Given this list of marker genes Calhm4, Calhm2, Calhm5, Calhm1, Calhm3, Slc17a9, P2rx7, Calhm6, Ank, Cd47, here is a description of the gene set: Mouse Gene Set: GOBP_ATP_EXPORT species: Mus musculus The directed movement of ATP out of a cell or organelle.